The following is a description of a gene set: studied in species Mus musculus Mouse Gene Set: REACTOME_NUCLEAR_PORE_COMPLEX_NPC_DISASSEMBLY Nuclear Pore Complex (NPC) Disassembly, and this is the list of marker genes: Sec13, Nup107, Ccnb1, Nup88, Aaas, Rae1, Nup155, Nup54, Nup42, Nup93, Nup214, Nup43, Nup210, Nup58, Ranbp2, Tpr, Nup133, Nup85, Nup37, Nup98, Nup188, Pom121, Nup62, Seh1l, Ndc1, Nup205 (nucleoporin 205), Nup50, Ccnb2, Nup35, Cdk1, Nup153, Nup160